The following is a description of a gene set: from publication Boquest AC, Shahdadfar A, Frønsdal K, Sigurjonsson O, Tunheim SH, Collas P, Brinchmann JE (PMID 15635089) Stromal stem cells proliferate in vitro and may be differentiated along several lineages. Freshly isolated, these cells have been too few or insufficiently pure to be thoroughly characterized. Here, we have isolated two populations of CD45-CD34+CD105+ cells from human adipose tissue which could be separated based on expression of CD31. Compared with CD31+ cells, CD31- cells overexpressed transcripts associated with cell cycle quiescence and stemness, and transcripts involved in the biology of cartilage, bone, fat, muscle, and neural tissues. In contrast, CD31+ cells overexpressed transcripts associated with endothelium and the major histocompatibility complex class II complex. Clones of CD31- cells could be expanded in vitro and differentiated into cells with characteristics of bone, fat, and neural-like tissue. On culture, transcripts associated with cell cycle quiescence, stemness, certain cytokines and organ specific genes were down-regulated, whereas transcripts associated with signal transduction, cell adhesion, and cytoskeletal +CD105+CD31- cells from human adipose tissue have stromal stem cell properties which may make them useful for tissue engineering. Genes up-regulated in cultured stromal stem cells from adipose tissue, compared to the freshly isolated cells. studied in species Homo sapiens Human Gene Set: BOQUEST_STEM_CELL_CULTURED_VS_FRESH_UP, and this is the list of marker genes: PIK3IP1, SORBS1 (sorbin and SH3 domain containing 1), APOLD1, NFIB, JUND, TNMD, MYC, DNAJB1, GPX3, EMP2, SCG5, MICAL2, PCLAF, FMO1, ABCA6, IGF1, GLS, TIMP4, ASPA, WNT5A, PIK3R1, EMC1, SYNPO, ACAN, SLC2A3, SPTBN1, PTPRD, ARHGAP6, DCLK1, NAMPT, ZC3HAV1, SEPTIN11, DUSP1, FHL2, PODXL, KLF4, FN1, OXTR, MARS1, MT1M, CFI, CDK1, TGFBR3, FRMD4B, VCAM1, IL33, CPE, NINJ2, A2M, AIMP2, ABCC4, JUNB, SLC31A1, MAOA, KCNS3, PLBD1, RHOB, GDF15, CXCL10, CAPN6, NDRG2, LMO3, IFITM1 (interferon induced transmembrane protein 1), ACSL5, FOXD1, COMP, FXYD1, ACACB, MT-ND5, G6PD, COLEC12, HAPLN1, BST2, ASPM, GGT5, PPP1R12B, RRM2, TNFSF10, MTSS1, TSC22D3, EIF2S2, CD44, ANK2, SLC7A11, SRGN, PDLIM5, COL14A1, MOCOS, MAN1A1, RGS5, IFI44, GEM, LINC01140, LRRC8B, DSP, MITF, HSPA1A, CCL2, CTSS, TNFRSF11B, ACKR3, TNFAIP3, LOXL2, MAP3K8, NTRK2, RPL26L1, RGS4, FAM13A, KCNAB1, TCIM, RPS6KA5 (ribosomal protein S6 kinase A5), NPR3, ELOVL2, DKK2, ING1, FLNC, TGM2, TRPC4, SERPINE2, SLC5A3, CCL8, PER3, KLHL24, DKK1, HBA1, TIGAR, UCHL1, NELL2, MEAK7, GPRC5A, GSDME, NQO1, SCRG1, HSPA6, DLGAP5, CDH2, CFH, IL6R, CLIC2, RGS2, CLEC3B, PEG3, CILP, EGFR, WARS1, MAFB, N4BP2L1, ETS2, KIF13B, BCHE, IER5 (NCBI Gene Id 51278), MMP1, LPL (lipoprotein lipase), PMAIP1, NRIP1, SPATA6, ANGPTL2, IARS1, PAPSS2, CXCL1, SLC16A3, RHOBTB1, IL15RA, TXNRD1, RAI2, EIF5 (eukaryotic translation initiation factor 5), MYLIP, KRT18, MATN2, LOX, FRZB, MCFD2, MOXD1, CEMIP, FOXO1, ACLY, TFPI, COCH, GUCY1A1, CHRDL1, DDAH1, ENPEP, PPARG, PPP1R3C, COL15A1, TPST2, NPY1R, SPTLC2, ITM2A, NFKBIA, MYBL1, CALU, TRIB3, CLMN, FAM117A, IRF1, ID1, ANKRD36B, MX2, BHLHE40, TPX2, ATF3, SLC38A1, EDNRB, LIMCH1, STC2, CYP1B1, CRLF1, GPC3, IGSF3, GREM1, SERPINE1, CLK1, SLC1A4, EIF1, MFAP4, RABGAP1, RAI14, ASNS, CBS, DNM1, CES1 (carboxylesterase 1), KCNK2, HSPB7, SRSF7, KRT7, AOC3, RORA, AKAP13, GPNMB, CD34, SRPX2, SOBP, ARHGDIB, EGR1, TPM2, CDKN1C, APOC1, ADGRG2, SULF1, CEP55, WSB2, PGM3, GREM2, CFHR2, ENG, ANG, RRAD, SYNM, COL18A1, DEPP1, TMT1A, RNASE4 (ribonuclease A family member 4), TGFB2, ZFP36, EPHA3, MET, COL4A5, C1QTNF3, SLC19A2, GADD45G, ATP8A1, SERPINF1, RND1, HBEGF (heparin binding EGF like growth factor), MAN1C1, TENM1, KLF11, SOD2, NACC2, SEL1L3, COL11A1, KLF6, PTGDS, SRPX, ANO1, HNRNPM, CCL3, CDK7 (cyclin dependent kinase 7), GAS7, RASL12, MARK1, FMO3, INHBA, PTGER2, HLF, CXCL8, POPDC3, TNFAIP6, ADAM22, GUCY1B1, SEMA3G, CLIC3 (NCBI Gene Id 9022), MX1, SHMT2, SRD5A1, CDC42EP3, DOK5, ADAM10, NOX4, SLC7A1, ME1, CXCL3 (C-X-C motif chemokine ligand 3), CHI3L1, ZBTB20, SLC43A3, PRKAR2B, SOX4, TXNIP (thioredoxin interacting protein), FGF2, DCN, TENM3, AKR1C1, RABGAP1L, SELENOP (selenoprotein P), MTUS1, TLR3, GFPT1, PLTP (phospholipid transfer protein), C6, BAX, TOP2A, HLA-DPA1, SYNC, ADH1C, ZBTB10, CRIP1, MYO10, CYP4B1, OASL, NR1H3, SLC7A5, SPRY2, GLIPR1, TP53BP2, TMEM135, CLEC2B, TPM4, TPGS2, CD302, CYLD, SAMHD1, IFIH1, ADH1B, TRIB1, ZBTB16 (zinc finger and BTB domain containing 16), ATF5, SLC43A1, GBP2, TMEM176A, PLXDC1, SLC1A1, RAP1GDS1, F10 (coagulation factor X), GADD45B, MELK, BMP2, LRP1B, CXCL2, CELF2, REL, RGS16, SSPN, ADAM12, NAP1L1, APOL3, NOVA1, FAXDC2, SELENBP1, PER2, APOE, PRELP, CYP26B1, TSPAN8, NEK7, PGK1, ERAP1, OMD, DCX, BTG2, CTSK, PFKFB3, PDK4, TMEM100, PRKD1, CPQ, CDO1, PPP1R15A, ESR1, CD83, HSPA1B, ADAMTSL3, GDF10, TPD52L1, PSAT1, JUN, LMO7, ECM2, MAF, STEAP4, CD9, GSN (NCBI Gene Id 2934), ITGA4, SPRY1, CCNL1, OLFML2A, RPS6KA2, FMO2, PAPPA, ABI3BP, MGP, ATP8B4, SERPINA3, AGTR1, ACTC1, FGL2, RUNX1T1, PRG4, TMPO, ALCAM, LTBP4, AEBP1, AP2S1, KLF9, ANGPTL4, PELI1, YARS1 (NCBI Gene Id 8565), THBS1